The following is a description of a gene set: The directed movement of one-carbon compounds into, out of or within a cell, or between cells, by means of some agent such as a transporter or pore. Mouse Gene Set: GOBP_ONE_CARBON_COMPOUND_TRANSPORT studied in species Mus musculus, and this is the list of marker genes: Car4, Umod, Aqp7, Hba-a1, Slc12a1, Car2, Upk3a, Aqp6, Rhcg, Aqp3, Hbb-bh1, Aqp9, Hbb-bs, Rhbg, Aqp5, Car12, Car14, Hba-x, Rhag, Aqp4, Slc14a1, Hbb-y, Slc14a2, Aqp8, Pou3f3, Aqp1